The following is a description of a gene set: Mouse Gene Set: GOCC_GERMINAL_VESICLE The enlarged, fluid filled nucleus of a primary oocyte, the development of which is suspended in prophase I of the first meiotic division between embryohood and sexual maturity. species: Mus musculus, and this is the list of marker genes: Oosp2, Aurka, Ncapd3, Gtf2b, Marcks, Stpg4